Given this list of marker genes Mndal, Cxcl10, Nup88 (nucleoporin 88, NCBI Gene Id 630141), Atp6v1d, Trim12a, Cycs, Casp3, Sertad1, Ifit3, Ube2d3, Spop, Anxa7, Calhm6, Snx2, Ripk2, Igkc, Clec10a, Prpf38a, Plekhf2, Pkib, Rsad2, Casp1 (caspase 1), Ppm1k, Parp10, Pphln1, Tmem106a, Pttg1, Psmb8, Cd40, Txndc17, Sat1, Ilrun, Dnajc7, Serpina3g, Psmb10, Eif2s1, Slc30a1, Parp12, Igtp, Mov10, Lap3, Fndc3a, Parp14, Stat1, Aida, H2-T22, Sgcb, Socs1, Herc6, Cd47 (CD47 antigen (Rh-related antigen, integrin-associated signal transducer)), Clic4 (chloride intracellular channel 4), Samhd1, Sh3glb1, Sass6, Klf6, Leprotl1, Plin2, Trim30d, Xrn2, Dnajb1, Sar1a, Srgn, Batf2, Procr, Cdkn1a, Marchf5, Tor1aip2, Epsti1, Ifi35, Ly86, Znfx1, Slfn9, Rap1b, Larp1, Lgals9, Etv6, Cldnd1, Fcgr4, Selenow, Gbp4, Usp15, Evi2a, Irgm2, Ifih1, Phf11d, Atp6v1b2, Txn1, Dcp2, Dnaja2, Jaml, Sppl2a, Oas3, Gbp3, Mafk, Lbr, Cited2, Gbp2, Dnaja1, Casp4, Scimp, Stat3, Rcc1, Ccl2, Rigi, Serpina3f, Sp140, Ifi44, Arl6ip5, Rsl24d1 (NCBI Gene Id 76822), Ncoa7, Zyx, Ccnd2, Zbp1, Rnf213, Rab8b, Psme2b, Bst2, Gbp5, Stat2, Tpgs1, Lgals3bp, Casp8, Xdh, Mmp13, Sp100, Hat1, Tor1aip1, Rap2c, Il15, Cmpk2, Fbxo6 (NCBI Gene Id 99978), Eif2ak2, Dbnl, Arhgap15, A4galt, Sap30, Ifi208, Clec2d, Gbp7, Themis2, Ifi211, Aldh1b1, Ccdc25, Oasl2, Ubc, Tma16, Nampt, Plaat3, Atad1, Tor3a, Ifitm3, Irf1, Frmd4a, Pfkp, Dram1, Keap1 (NCBI Gene Id 54157), Etnk1, Slfn2, Chmp4b (NCBI Gene Id 96954), Adar, Pigf, Peli1, Cd69, Jpt1, Ifi207, Ifi213, Pi4k2a, Daxx, Ms4a4c, Ascc3, Yipf6, Ifit1, Ywhaz, Ociad1, Uaca, Rmdn3, Lrrc8c, Rtp4, 9930111J21Rik2, Ms4a6d, Ifit3b, Zfp281, Slfn8, Tra2a, Tspo (translocator protein), Pim1, Mpp1, Azi2, Pnpt1, Ifi204, Tap1, Klrk1, Sco1, Mcmbp, Ccl7, Ms4a6b, Brd2, Sp110, Usp18, Prkx (NCBI Gene Id 19108), Ccl9, Phf11a, Calm1, Max, Tnfaip1, Gatm, Trafd1, Rin2 (Ras and Rab interactor 2), G3bp2, Tcstv4, Parp11, Usp25, Tmod3, Cpne3, Trim30a, Cd274, H3f3b, Map2k1, Nup210, Anxa4, Svbp (small vasohibin binding protein), Ccl12 (C-C motif chemokine ligand 12), Pnp, Ms4a4b, Ogfr, Zup1, Ppa1, Tnfsf10, Ms4a6c, Parp9, Ifit2 (interferon-induced protein with tetratricopeptide repeats 2), Oas1a, Isg20, Carmil1, Rufy3 (NCBI Gene Id 72186), Ifi206, Srsf3, Nt5c3, Ubd, Phf11b, Mxd1, Trim56, Katna1, Cebpb, Tpx2, Il27, Ccdc71l, Oasl1, Cxcl9, Ifi214, Xaf1, Crlf3, Slc25a22, H2-T23, Ank2, Rbms1, Dek, Csrp1, Iigp1, Il15ra, Ppp1r2, Ifi205, Mlkl, Creb3, Ctsc, Ifi47, Gbp8, Mitd1, Ch25h, Nmt2, Dtx3l, Cnp, Dck, Hspa5, Trim30c, Ranbp2, Mbd2, Mthfr, Gnb4, Glipr2, Ddx4, Dhx58, Samd9l, Fcgr3, Myh10, Ccl8, Fam53c, Mx1, Oas2, Slfn5, Irf8, Hnrnph2, Arl4a, Fam241a, Irf7 (NCBI Gene Id 54123), Fcgr2b, Psmb9, Gch1, Ddx60, Fcgr1, Wars1, Ube2l6, Ifi209, Irgm1, Isg15, Ifi203, Tmem229b, Psme1, Gbp9, here is a description of the gene set: species: Mus musculus Genes positively differentially expressed in cell type: Macrophage upon treatment with cytokine: IFN-β in mouse lymph nodes in vivo. from publication Cui A, Huang T, Li S, Ma A, Pérez JL, Sander C, Keskin DB, Wu CJ, Fraenkel E, Hacohen N (PMID 38057668) Cytokines mediate cell-cell communication in the immune system and represent important therapeutic targets. A myriad of studies have highlighted their central role in immune function, yet we lack a global view of the cellular responses of each immune cell type to each cytokine. To address this gap, the authors created the Immune Dictionary, a compendium of single-cell transcriptomic profiles of more than 17 immune cell types in response to each of 86 cytokines (>1,400 cytokine-cell type combinations) in mouse lymph nodes in vivo. A cytokine-centric view of the dictionary revealed that most cytokines induce highly cell-type-specific responses. For example, the inflammatory cytokine interleukin-1β induces distinct gene programmes in almost every cell type. A cell-type-centric view of the dictionary identified more than 66 cytokine-driven cellular polarization states across immune cell types, including previously uncharacterized states such as an interleukin-18-induced polyfunctional natural killer cell state. Mouse Gene Set: CUI_MACROPHAGE_IFNB_RESPONSE_UP